Given this list of marker genes Casp4, Birc3, Ubb, Casp3, Casp8, Bak1, Il1a, Bax (BCL2-associated X protein), Chmp2b, Prkn, Gsdmd, Cdc37, Cycs, Rps27a, Tradd, Fas, Casp1, Hmgb1, Gzmb, Flot2, Sdcbp, Fadd, Flot1, Fasl, Elane, Chmp2a, Mlkl, here is a description of the gene set: part of: Programmed Cell Death Reactome Pathway: Regulated Necrosis species: Mus musculus This event has been computationally inferred from an event that has been demonstrated in another species.<p>The inference is based on the homology mapping from PANTHER. Briefly, reactions for which all involved PhysicalEntities (in input, output and catalyst) have a mapped orthologue/paralogue (for complexes at least 75% of components must have a mapping) are inferred to the other species. electronically inferred by orthology from the curated human pathway